Given this list of marker genes ANKRD39, NKX2-2, KCNB2, TRRAP, LRRK1, TNPO2 (transportin 2), TEPSIN, DAAM2, ARID4B, EP300, EIF3B, JMJD6 (jumonji domain containing 6, arginine demethylase and lysine hydroxylase), DAZAP1, ID1, CBLN1, IRX4, JUNB, SMAD3, KREMEN2, SLC20A1, RTL9, ATOH1, CACNB2, LHFPL1, BCL2L2 (NCBI Gene Id 599), SLC25A3, C14orf119, OMG, PHF12, SLITRK1, SLC25A28, ACIN1, R3HDM1, AMPH, CCDC177, PTPRT, KCNN1, GGPS1, SMAD2, PBX1, SOWAHA, TRERF1, FGF12, here is a description of the gene set: Genes having at least one occurrence of the motif CAAGTGCGTG in the regions spanning 4 kb centered on their transcription starting sites. This matches the HMX1 transcription factor binding site V$HMX1_01 (v7.4 TRANSFAC). studied in species Homo sapiens Human Gene Set: HMX1_01